Given this list of marker genes NUDT21, TMEM41A, TMEM185B, ELAVL1, NUDCD2 (NudC domain containing 2), CXADR, VPS13A, LCP1, LACTB (NCBI Gene Id 84943), UPF2, ZNF10, PCSK5, TSC22D2, PTGR3, SLC35D1, TMEFF2, KIAA0825, VSTM2A, MAP4K3, LRP4, ASB5, SNAPC3, ATXN1L, MAN1A2, PFDN4, PARVA, CCDC71L, DNAJC15, SYTL4, ZNF367, WNT5A, C8orf88, UBE2N, ADD1, HMBOX1, OXR1, SMIM13, ZFY (NCBI Gene Id 7544), ATAD2B, SLC35F5, EIF1AX, ARID2, GALNT3, NME5, FURIN (NCBI Gene Id 5123), NSUN5, MXD1, PANK3, SH2D1A, CEP170, MEX3D, DPY19L1, ASCL4, SRSF6, RFX7, PHF6, CPEB2, ZFP91, MTMR9, FSBP (fibrinogen silencer binding protein), PDCD6IP (programmed cell death 6 interacting protein), EMILIN2, LAMC2, GTF2H3, PGK2, CPEB3, GPR68, STRIP2, TDRD6, CEBPD (CCAAT enhancer binding protein delta), DYNLT5, CAMK4, KIF21A, ENKUR, PARG, OSBPL6, TPMT, SLC11A2, CTNNB1, UBTD2, EIF1AY, PBOV1 (NCBI Gene Id 59351), TMEM135, JAZF1, HSFY2, RET, PDE10A, WWP1, ZNF281, ZNF407, CDC73, FAM98A, ECE1, FNTA (NCBI Gene Id 2339), OR51E1, NLRP1, ING3, FAM241A, PDK1, MAN1C1, FAM81A, ZNF354A, MAGT1 (NCBI Gene Id 84061, magnesium transporter 1), AOPEP, CDK17, ZC3H12C, HSFY1, ZBTB34, ZC3HAV1, ZNF516, CPSF7, PROK2, KAT2B, SLC33A1, MACF1, CPSF6, SEMA6A, here is a description of the gene set: species: Homo sapiens from publication Chen Y, Wang X (PMID 31504780) Human Gene Set: MIR885_5P Genes predicted to be targets of miRBase v22 microRNA hsa-miR-885-5p in miRDB v6.0 with MirTarget v4 prediction scores > 80 (high confidence targets).